Given this list of marker genes CASP2, NCF2, MYRF, STRN3, IQGAP3, SOX8, RGS1, DUSP4, AGR2, CRIP1, SRSF6, MTA2, TRIM7, PLA2G4A, PDE10A, ZIC2, MUC5AC, MST1, GAD1, USF1, RAB27B, MT1E, IFI6, ETV5, REG4, EIF5A, MIR497HG, MST1P2, TFAP2A, HNRNPL (NCBI Gene Id 91538), here is a description of the gene set: Promoter methylation of the mismatch repair gene plays a key role in sporadic microsatellite instability (MSI) colorectal cancers. However, promoter methylation often occurs in proximal colon cancers, and molecular phenotypes underlying MSI cancers in distal colon have not been fully clarified. Our goal was to clarify the difference between MSI and microsatellite stability (MSS) cancers and, furthermore, to determine distinct characteristics of proximal and distal MSI cancers. By DNA microarray analysis of 84 cancers (33 MSI and 51 MSS), we identified discriminating genes (177 probe sets), which predicted MSI status with a high accuracy rate (97.6%). These genes were related to phenotypic characteristics of MSI cancers. Next, we identified 24 probe sets that were differentially expressed in proximal and distal MSI cancers. These genes included promoter methylation-mediated genes, whose expression was significantly down-regulated in proximal MSI cancers. Among discriminating genes between MSI and MSS, nine methylation-mediated genes showed down-regulation in MSI cancers. Of these, 7 (77.8%) showed down-regulation in proximal MSI cancers. Furthermore, methylation-specific PCR confirmed that frequency of hMLH1 promoter methylation was significantly higher in proximal MSI cancers (P = 0.0317). These results suggested that there is a difference between proximal and distal MSI cancers in methylation-mediated influence on gene silencing. In conclusion, using DNA microarray, we could distinguish MSI and MSS cancers. We also showed distinct characteristics of proximal and distal MSI cancers. The inactivation form of hMLH, per se, differed between proximal and distal MSI cancers. These results suggested that distal MSI cancers constitute a distinct subgroup of sporadic MSI cancers. from publication Watanabe T, Kobunai T, Toda E, Yamamoto Y, Kanazawa T, Kazama Y, Tanaka J, Tanaka T, Konishi T, Okayama Y, Sugimoto Y, Oka T, Sasaki S, Muto T, Nagawa H (PMID 17047040) Up-regulated genes discriminating between MSI (microsatellite instability) and MSS (microsatellite stability) colon cancers. Human Gene Set: WATANABE_COLON_CANCER_MSI_VS_MSS_UP species: Homo sapiens